Given this list of marker genes MRRF (NCBI Gene Id 92399), ANKRD11, MME, PRKCB, GADD45B, PIK3R1, RAB2B, MDM2, ARHGEF5, MMP1, TGFBR2, PPP1R15A, ABL2, DDIT3, AHRR, ADAMTS13, SEMA4F, SEMA3C, ARHGAP23, MZB1, SEMA6A, RAB27B, PPP1R3C, SEMA6D, here is a description of the gene set: Genes up-regulated in glioma cell lines after knockdown of SPARC by RNAi. Human Gene Set: SHI_SPARC_TARGETS_UP studied in species Homo sapiens from publication Shi Q, Bao S, Song L, Wu Q, Bigner DD, Hjelmeland AB, Rich JN (PMID 17213807) Secreted protein acidic and rich in cysteine (SPARC) is an extracellular glycoprotein expressed in several solid cancers, including malignant gliomas, upon adoption of metastatic or invasive behaviors. SPARC expression in glioma cells promotes invasion and survival under stress, the latter process dependent on SPARC activation of AKT. Here we demonstrate that downregulation of SPARC expression with short interfering RNA (siRNA) in glioma cells decreased tumor cell survival and invasion. SPARC siRNA reduced the activating phosphorylation of AKT and two cytoplasmic kinases, focal adhesion kinase (FAK) and integrin-linked kinase (ILK). We determined the contributions of FAK and ILK to SPARC effects using SPARC protein and cell lines engineered to overexpress SPARC. SPARC activated FAK and ILK in glioma cells previously characterized as responsive to SPARC. Downregulation of either FAK or ILK expression inhibited SPARC-mediated AKT phosphorylation, and targeting both FAK and ILK attenuated AKT activation more potently than targeting either FAK or ILK alone. Decreased SPARC-mediated AKT activation correlated with a reduction in SPARC-dependent invasion and survival upon the downregulation of FAK and/or ILK expression. These data further demonstrate the role of SPARC in glioma tumor progression through the activation of intracellular kinases that may provide novel therapeutic targets for advanced cancers.